The following is a description of a gene set: Any process that modulates the frequency, rate or extent of the activity of the inositol 1,4,5-trisphosphate-sensitive calcium-release channel. studied in species Mus musculus Mouse Gene Set: GOBP_REGULATION_OF_INOSITOL_1_4_5_TRISPHOSPHATE_SENSITIVE_CALCIUM_RELEASE_CHANNEL_ACTIVITY, and this is the list of marker genes: Myo5a, Pkd2, Htt, Asph, Hap1